The following is a description of a gene set: from publication Yevshin I, Sharipov R, Kolmykov S, Kondrakhin Y, Kolpakov F (PMID 30445619) Mouse Gene Set: HDGFL2_TARGET_GENES Genes containing one or more binding sites for (Hdgfl2) in their promoter regions (TSS -1000,+100 bp) as identified by GTRD version 20.06 ChIP-seq harmonization. species: Mus musculus, and this is the list of marker genes: Snapc5, Anapc7, Shc2, Prpf39, Hsp90aa1, Atp5f1b, Tlk2, Prelid1, Polr2m, Vars1, Vdac3, H2ac15, 1110038B12Rik, Snord38a, Ahsa2, Cdc14b, Snora21, Csde1 (cold shock domain containing E1, RNA binding), Cyth2, Gm13228, Dzank1, Rell1, Ing4, 6030442K20Rik, C87436, Epha2, Odad4, Emc1, Taf9, Rilp, Gm16861, Ndufb10, Iqcg, Abcg2, Gcat, Mir6936, Usp1, Cdk1, Chmp2a, Znfx1, Polg2, Mir293, H2ac22, Mir6935, Eif4a2, Gm10382, Mir6927, Snord35a, Rps27a, Arfrp1, Gm22455 (predicted gene, 22455), Igf2, Mir150, Snhg8, Use1, Hnrnpk (heterogeneous nuclear ribonucleoprotein K), 2410002F23Rik, Nudt3, Wdr83os, Snord47, Sra1, Ints6, Snora52, Eif1, Cyb5r1, Tedc2, Tesmin, Chtop, Mir130a, Duxf1 (double homeobox family member 1), Mdh2, Ctcf, Gm22589, Tmco4, Eapp, Snora7a (NCBI Gene Id 100217451), Spmap1, Eif2s3x, Ccdc97, Maml1 (NCBI Gene Id 211871), Dok3, Gm24134, Rabggtb, Zfas1, Kpnb1 (karyopherin subunit beta 1), Gm23639, Rbm4b (RNA binding motif protein 4B), Etv5, Snhg7os, Dph6, Cebpzos, Gps2, Snora68, Srrm2, Ppp1r10, Tomm40, 1700052K11Rik, Stam, Gm6305, Mbtps1, Snora43, Suclg1, Dync1li2, Denr, Snora41, H2az1, H3c2, Atf4, Nktr, Snord58b, Cimip2a, Unc13d, Pabpc1, Sdcbp, Aimp1, Pnldc1, Nfatc2ip, Thrap3, Adk, Dzip3, Paip1, Gm22711, Snora31, Pkp4, Tardbp, Ufm1, Tuba1b (tubulin, alpha 1B), Lyrm4, Timm21, Spaca4, Snord2, Wdr83, Ptov1, Micos10, Actr10, mt-Co2, Snord68, Snhg5, Rpl21, Wdr77, Gm8357, Hrob, Ccdc103, Hnrnpa3, Gt(ROSA)26Sor, Hnrnpdl, Rif1, Zfp114, Spib, Rps7, H2bc21, Id3, Mapkapk5, 4932442E05Rik, Mir290b, Pole4, Rps17, Cog4, Yod1, Rpl36a, Kmt2a, Alkbh5, Fnbp4, Eci1, 4833413E03Rik, Agbl2, Gm26885, mt-Nd2, Slc2a3, Gm15564, B3galt4, Ccl25, Ccnb1, Sf3b3, Mir6945, Tfeb, Slc25a39, Trim39, Rrp36, Nme4, Rad17, Igfbp2, Zfp335os, 4930519P11Rik, Usp48, 5031425E22Rik, Snora9, Zc3h4, Gm6283, Snora16a, H2ac18, Elmo3, Psmd12, Actb, Tsc22d1, Gm23301, Rdh10, Mast1, Atxn7l3, Gm27011, Rbm39 (RNA binding motif protein 39), Banp, Snora3, Srsf2, Gm22879, Nup88, Nup205, Mir292b, Sart3, Qrich1, Ctsa, Blcap, mt-Ti, Rpl15, Rpl23 (NCBI Gene Id 80497), Skp1, Abcf3, Gtf3c4, Eef1g, Pcbd2, Golm2, Tmed1, B230369F24Rik, Polr2e, Snx5, Cmya5, Zfp661, Mir3064, Ndufa4, Pagr1a, Cdc45, Kmt2e, mt-Tq, Cenpx, Arf4os (ADP-ribosylation factor 4, opposite strand), Atad2b, Sucla2, Gusb, Usp53, Dennd6b, Nhlrc3, Rps23, Nme6, Ubtf, Ddx27, Rfc5, Sfpq, Ccnd3, Man2c1, Fbxl20, Znhit2, Cep76, Gmip, Ccdc121, Rab8b, Aldoa, Myl12b, Rbbp5, Pikfyve, mt-Tm, Ube2m, Raf1, Dazap1, Ajm1, Ube2i, Psph, Pcyt1b, Tut4, Eif4a1, Helq, Csnk1g2 (casein kinase 1, gamma 2), Gm13427, mt-Ta, Hnrnpf, Mir8094, 0610009L18Rik, mt-Tp, Ndufs1, Snora33, Snhg12, Pdss1, Ncln, Jade1, Tektip1, Uqcr11, H2bc18, Luc7l3, Ndc1 (NDC1 transmembrane nucleoporin), Rps8 (ribosomal protein S8), 4933440N22Rik, Cox20, Niban3, Gm15247, Hs2st1, Cnih2, Coq3, Snord80, Mettl23, Gm13015, Cpsf6, Rprd2, Gpx1, Ube2d3, Ubr4, Gm22620, Mzt2, Maz, Ankle2, Gm24698, Irgq, Msantd2, Stx5a, Smc2os, Mir295, Prrt2, Gm25789, Zfpl1, Cad, BC028777, Tmem230, Ufd1, Vcf1, Mir6988, Rps12, Rack1, Zfp410, Dgat1, Psen1, H2bc11, Ube2g2, Snord32a, Mtnap1, Gm31266, Kdm1a, Sulf2, Nup85, Trmt2a, BC046401, C130036L24Rik, Rpl31, Ankrd40cl, Pbx2, Rab26, Arf3, Sdhd, Snord45c, Snora5c, Tlcd1, Hat1, Snord59a, Eno1, Hspa9, Gm11335, Nop2, Rtn4, Cdh24, Ssbp2, H3c15, Snhg15, Rpl5, H2bc13, Gm24523, Dgkz, Bckdha, Gm12694, Zfand5, Clhc1, Brd8dc, Cox7a2l, Nsun3, Ddx5, Ilk, Cdkn1a, Zranb2, Zcchc14, Slc17a9, Tbx6, Dnah8, Eif2s3y, Bud13, Caprin1, Ptprcap, Mir7079, 2610005L07Rik, Snord78, Eef1b2, Ngrn, Gm25791, Sema3f, Pygo2, Sec61b (SEC61 translocon subunit beta), B4galnt1 (NCBI Gene Id 71257), Mfsd11, Gm32996, Tssk6, Fbxo11, Akap11, Rpl9, Mir7653, Eif4enif1, Ints5, Hmgn2, G530011O06Rikx, Anapc11, Gm24888, 3000002C10Rik, Ipo13, Gm15816, Nkiras1, Snora64, Epas1 (NCBI Gene Id 13819), Srd5a1, Utp14b, Snora73b, Cd2bp2, Rps14, A430057M04Rik, Rcc1, Atp6v1d, Cnbp, Fubp1, Sh3d21, Rpl35a, Rps9, Kdm6b, Klf11, Arf4, Rpn1, Tjp1, Snora61, Gga3, Nsun2, Mrpl21 (mitochondrial ribosomal protein L21), Fgf18 (NCBI Gene Id 319384), Bclaf1, Cd68, 4930539J05Rik, Ube2q2, Gng14, Patz1, Uqcr10, H4c8, Rps19, Cct6a, Mrps2, Fgfr3-ps, Ccnt1, Peg10, Rps18, Lamp1, Sntb2, Gm13034, Prdx1, Gm22571 (NCBI Gene Id 115487260), Cdc73, Actg1, Tpd52-ps, Ncl, Mab21l3, Rps15a, Zc3h10, Zbtb47, Tbrg4, Ybx1 (NCBI Gene Id 97156), Pi4kb, Cnot8, Lrr1, Abl1, Med28, Ak6, Pym1, Rexo1, Gm14861, Gm25744, Ahdc1, Gtf2e2, Snora65, Snora74a, Gm24044, Upf2, 5830454E08Rik, Rpl27, Brd2, Sar1a, Zfp90, Mms22l, Gm23925, Gnb1, Tbck, Stamos, Snrpg, Pes1, Cstb, Matr3, Ankfy1, Atn1, Fam219b, Dnaaf10, Snord95 (small nucleolar RNA, C/D box 95), Slc30a1, Psmg2 (NCBI Gene Id 75651), Rpl13a, Gm10143, H2ax, C130032M10Rik, Gm24313, Klc3, Fam162a, Sumf2, Farsb, H4c1, mt-Tv, Atf1, Eftud2, Taf6l, Vps39, H2bc12, Mcts2, Rpl6, Snora75, Gm10785, mt-Ty, Osbpl1a, Acin1, Rps2, Eef1a1, Septin4, Gramd1a, Zfp219, Brme1, Naa25, Rcc2, Pithd1, Cbx3, Supv3l1 (suppressor of var1, 3-like 1 (S. cerevisiae)), Rsrp1, Mysm1, Gm13421, Ddx31, Ddx39b, Rpl3, Bcl3, Slc27a3, Rps11, Pcgf2, 6330562C20Rik, Smc2, Dapk3, Gorab, Timm8b, Lrrc47, Gtf2a1, Gapdh, Mllt6 (myeloid/lymphoid or mixed-lineage leukemia; translocated to, 6), Kansl1, Gm23344, Gnb2, Atp5mg, Tssc4, Ahctf1, Tsn, AI480526, Klf3, 2310040G24Rik, Crebzf, Gm24029, Snord43, Selenof (NCBI Gene Id 93684), Rapgef1, Klf6, Eif4g2, Mrto4, Rbpms, Gm26387, Gm43403, mt-Td, Meg3, Zbtb40, Ighmbp2, Proser1, mt-Tw (mitochondrially encoded tRNA tryptophan), Podxl2, Exo1, Cldn7, Nadk, Rfc4, Gcn1, Abcc1, H2bc8, Dnajb14, Slc3a1, Ndufa11b, Rpl18, Chd4, Rpl7a, Snora44, Nop58, C230096K16Rik, Hexim1, Scamp5, Trim28, Urm1, Atp5pb, Bola1, Mir21a, Rtel1, Rpl28, Tspan31, Setd5, Eml3, Ccnd3-ps, Ifi35, Timmdc1, Snord73b, Apex1 (NCBI Gene Id 11792), Cox4i1, Rps10, Rpl10a, Jmjd8, Macf1, Psmd1, Gm24455, Rpl34, Flna (NCBI Gene Id 245705), Atp5f1a, Gm24016, Hnrnpl, Mrps7, Mir6236, H2ac8, Rps20, Med22 (NCBI Gene Id 99421), Gm26330, Smim27, Kank3, Agbl3, H4c9, Gzmm, H3c4, Son, Rpl26, Hdlbp, Dipk1b, 4930592C13Rik, Srsf3, Gm12925, Msh4, Atcayos, Gm13162, Pdap1, Rad23a, Eif5a, Qng1, Cip2a, Pin4, Donson, Tgif1, Mir7067, Pfkfb2 (6-phosphofructo-2-kinase/fructose-2,6-biphosphatase 2), Kdm4b, Gm11583, Zfp82, Ftl1, Sap25, Ifrd1, Gramd2a, mt-Tc (NCBI Gene Id 17727), Chd2, Tsg101, Pno1, Aldoc, St13 (NCBI Gene Id 70356), Snord57, Rps15, Ganab (NCBI Gene Id 14376), Surf1 (NCBI Gene Id 80523), Gm23212, Rnf225, Myh9, Tipin, Zmat5, Vti1b, Suds3, Gtf2h1, Rap1b, Mpv17 (MpV17 mitochondrial inner membrane protein), Mrps5, Gm25878, Bag6, AA474408, Spef1, Gm26397, Rdh5, Tm9sf1, Mrpl11, Cactin, Efcab2, Gm19325, Nfyb, Snhg9, Srsf1, Gm15420, mt-Tn, Mir671, Vdac2, Rnf167, Rbm4, Cep295 (NCBI Gene Id 399598), Gas5, Erc1, Maip1 (matrix AAA peptidase interacting protein 1), Mrps18b, Gm26448, Mapk14, Hps5, Tyw5, Rpl7, Scrn2, Cpt1a, Elk4, Csnk1e, Inpp5e, Cers2, Zfp850, Slc25a11, Rab33b, Bud31 (BUD31 homolog), Sfi1, Arhgap11a, Rex1bd, Gtsf1l (NCBI Gene Id 68236), Gm23201, Ttc8, Mcm10 (minichromosome maintenance 10 replication initiation factor), Iffo1 (intermediate filament family orphan 1), Gm23130, Hnrnpu, Rplp2, 6820431F20Rik (RIKEN cDNA 6820431F20 gene), Gtf3c6, H2ac6, Fam76a, Ubxn6 (UBX domain protein 6), Mylpf, Rhbdl1, Amotl2, Sinhcaf, Gm10222, Ap2a1, Osgep, mt-Rnr2, Bcl2l11, Hadhb, Pum3, Slc35b1 (solute carrier family 35, member B1), Uba52, Rabl2, Gm29417, Tomm20, Kat2a, Cep170b, Lpcat3, Gm26457, Rps23rg1, Hadha, Snord12, Krtcap3, Ugdh, H2bc15, Mir6965, Mir1938, Cdca5, Ice1, Iscu, Lasp1, Sirt4, Notch2, Mir7069, Styxl1, Safb, Alkbh1, Alg2, Gm12516, H3c10, Cdk12, Gm25541, Mgme1, AI506816, Stam2, Gm10250, Gm19553, Mir1894, Snora17, Tpm1, Rmc1, Srsf5, Pdf, Amdhd2, Snord34, Paf1, Polr3f, Impdh2, Epn1, Secisbp2, Pcna, Mid1, Gm7008, Exosc5, Xpnpep3, Phf14, Dctn1, Ap3m1, Snora24, Zfp341, Gm11399, Mir294, Paip2, Mir7650, Idh3b